Given this list of marker genes ATRX, DAXX, here is a description of the gene set: Many tumors that are positive for markers of alternative lengthening of telomeres (ALT) harbor loss-of-function mutations in the ATRX gene, encoding a chromatin remodeling protein ATRX. ATRX is thought to act together with DAXX and histone H3F3A to inhibit DNA recombination at telomere ends. For review, please refer to Heaphy et al. 2011, Gocha et al. 2014, Pickett and Reddel 2015, Amorim et al. 2016. Reactome Pathway: Defective Inhibition of DNA Recombination at Telomere Due to ATRX Mutations part of: Defective Inhibition of DNA Recombination at Telomere studied in species Homo sapiens